The following is a description of a gene set: Human Gene Set: HP_CARDIORESPIRATORY_ARREST species: Homo sapiens Cardiorespiratory arrest, and this is the list of marker genes: SCO2, KIT, SLC2A10, LAMP2, DDC, GET3, SLC25A20, TSPYL1, MYL2, TXNDC15 (NCBI Gene Id 79770), GPX4, ADGRG6, COL2A1